Given this list of marker genes Derl2, Ids, Ctbs, Bend5, Osm, Kremen2, Cask, Asic1, Bach2, Prrt3, Pphln1, Zfp850, Pip5k1b, 4930513O06Rik, Insyn2a, Hoxa9, Ppp3ca, Nexmif, Bhlhe40, Arhgap35, Mdc1, Sh3glb1, Scg2, Tnpo2, Fam107a, Ppfia1, Col4a1 (collagen, type IV, alpha 1), Znfx1, Nxf2, Omg, Pappa2, Zdhhc9, Hectd3, Actr3, Prkd3 (protein kinase D3), Tead2, Cert1, Ubr7, B3galt6, Abhd17b, Ppwd1, Clip4, Akap8, Krtap2-4, Seh1l, Dynlt3, Klhl24, Spopl, here is a description of the gene set: Genes predicted to be targets of miRBase v22 microRNA mmu_miR_7074_3p in miRDB v6.0 with MirTarget v4 prediction scores > 80 (high confidence targets). from publication Chen Y, Wang X (PMID 31504780) Mouse Gene Set: MIR_7074_3P studied in species Mus musculus